The following is a description of a gene set: Mouse Gene Set: GOMF_VOLTAGE_GATED_POTASSIUM_CHANNEL_ACTIVITY studied in species Mus musculus Enables the transmembrane transfer of a potassium ion by a voltage-gated channel. A voltage-gated channel is a channel whose open state is dependent on the voltage across the membrane in which it is embedded., and this is the list of marker genes: Pkd2, Kcne1 (NCBI Gene Id 16509), Kcnj13, Kcng1, Kcns3, Cav1, Kcng3, Kcnk7, Kcnd1, Kcnma1, Kcnn4, Kcna4, Kcnk6, Scn2b, Kcnk13, Kcnf1, Kcnk18, Kcnc2, Kcnv2, Kcnk12, Kcnk2, Hcn1, Kcnh5, Lrrc26, Kcna7, Kcnb1, Kcnab1, Kcnj14, Kcna5, Kcnn3, Kcnc1, Kcnk16, Hcn3, Kcnk10, Kcnh2, Kcnc4, Kcnh1, Kcnk1, Kcnj1, Lrrc52, Kcnj5, Kcnn2, Kcnj15, Kcnab2, Kcnt2, Kcnh7, Kcnh4, Kcnd2, Kcnab3, Kcnc3, Lrrc38, Cnga2, Kcnh8, Kcnj9, Kcnh6, Kcne2, Kcnk9, Kcna2, Lrg1, Kcnk3, Kcna1, Kcne4, Kcnj2, Hcn4, Kcns1, Kcnj6, Kcnv1, Kcnq3, Kcnb2, Lrrc55, Kcnj12, Kcnq1, Kcns2, Kcnip2, Kcnj11, Kcne5, Kcne3, Kcnk5, Kcnh3, Kcnj16, Kcnj8, Kcnj10, Kcnt1, Kcna10, Hcn2, Kcnn1, Kcnq2, Kcna3 (NCBI Gene Id 269476), Kcnj3, Kcnj4, Kcnq4, Kcna6, Kcnq5, Kcnd3, Kcng4, Kcnk4, Snap25